The following is a description of a gene set: Mouse Gene Set: GOBP_POSITIVE_REGULATION_OF_GROWTH_HORMONE_SECRETION Any process that increases the frequency, rate or extent of the regulated release of growth hormone from a cell. species: Mus musculus, and this is the list of marker genes: Ghrhr, Serp1, Ghrh, Itsn1, Arhgef7, Ghrl, Gabbr1, Drd2, Oga, Adcyap1, Kiss1, Selenot